The following is a description of a gene set: Human Gene Set: GOMF_POLYPEPTIDE_N_ACETYLGALACTOSAMINYLTRANSFERASE_ACTIVITY studied in species Homo sapiens Catalysis of the reaction: UDP-N-acetyl-D-galactosamine + polypeptide = UDP + N-acetyl-D-galactosaminyl-polypeptide. This reaction is the modification of serine or threonine residues in polypeptide chains by the transfer of a N-acetylgalactose from UDP-N-acetylgalactose to the hydroxyl group of the amino acid; it is the first step in O-glycan biosynthesis., and this is the list of marker genes: GALNT15, GALNT14, GALNT16, GALNT10, GALNT5, GALNT13, GALNT17, GALNT18, GALNT1, GALNT8, GALNT4, GALNT12, GALNT9, GALNTL6, GALNT6, GALNT7, GALNT3, GALNT11, GALNT2